The following is a description of a gene set: Neighborhood of ERCC2 Neighborhood of ERCC2 excision repair cross-complementing rodent repair deficiency, complementation group 2 (xeroderma pigmentosum D) in the MORF expression compendium studied in species Homo sapiens Human Gene Set: MORF_ERCC2, and this is the list of marker genes: BPHL, DIMT1, PIGF, RASSF1, PAX8, PRELID3A, DPT, PCGF1, CHD3, NUMB, MTX1, GLE1, CHD9, DDB1, TAF5L, KRT33A, JRK, EIF5B, IMPA1, FRYL, OARD1, MRE11, BAHD1, TLN2, SEC31A, ZNF592, SIK3, MPST, CSTF3, CLP1, NKRF, TAF2, PLEKHB1, LEPROTL1, KIAA0586, PIK3CB, EXTL3, AMFR (NCBI Gene Id 267), MGAT1, ATRX, SPEF1, BTD, PAX9, DNAJC7, FDXR, CLPX, GSK3B, NFYB, NEK9 (NCBI Gene Id 91754), AGPS, TRIM27, RAP1A, HNRNPL, RBBP8, PARVB, SCAMP1, INTS10, NFRKB, PEX6, CAMK2G, B4GALT3, TBC1D22A, ERCC2, SLC24A1, CPSF4, MUTYH, PIGB, ZNF500 (zinc finger protein 500), GRIK5, CDK13, ENTREP1, P4HA1, SLC30A3, MT4, DOK1, INPP5E, MC2R, SFSWAP, PSMF1, SSTR5, HTR7, KLHL18, WDR62, PAXIP1, LAIR1 (leukocyte associated immunoglobulin like receptor 1), GPATCH8, ITIH4 (NCBI Gene Id 3701), SLC25A11, TPR, PLIN3, DENND4A, SH2B1, PIGR, SLC22A24, GRIP2, FANCG, TMEM94, RERE, TMEM11, MFN2, PPP5C, TTI1, IRF2, RFC1 (replication factor C subunit 1)